Given this list of marker genes SLCO1B7, CETP, TSPO, PITPNM1, ABCA12, ANO4, ANO3, ABCA13, SLC10A4, TRIAP1, SERINC3, RFT1, CD36, VDAC2, PITPNC1, SLC10A6, STAR, SLC51B, SLC51A, CPTP, RBP4, ABCA7, SLC27A2, ABCD3, PITPNM2, SLC22A8, ABCA8, STARD5, ATP9B, SERINC5, ATP10A, STARD3, ATP11B, NPC1, ABCC3, ABCD2, ATP8A1, CIDEA, SLC22A6, ATP10B, SLCO2B1, APOD, SERINC2, PRELID1, XKR8, SLC43A3, ABCA2, APOA2, ABCA6, APOM, ATP8B2, APOB, SLC27A1, TMEM30A, PITPNA, ATP11C, ABCC11, AKR1C4, SLCO1B1 (solute carrier organic anion transporter family member 1B1), SCP2, CIDEB, ATP10D, XKR4, ATG2A, ANO6, OSBPL10, PLEKHA8P1, OSBPL5, ABCC1, ABCA1, ABCA5, SLC10A5, ANO9, ABCG8, TNFAIP8L3, SLCO1A2, SLCO4A1, SLC5A8 (NCBI Gene Id 160728), ABCG2, PRELID2, STARD7, SLCO2A1, BLTP1, ABCA3, PLSCR1, SFTPA1, ATP8B3, OSBP, APOF (NCBI Gene Id 319), TMEM30B (NCBI Gene Id 161291), SLC27A6, PCTP, TMEM63A, MFSD2B, OSBPL9, GRAMD1C (GRAM domain containing 1C), OSBPL1A, ATP9A, CERT1, VMP1, SLC2A1, PITPNM3, ATG9B, PRELID3A, SLCO1B3-SLCO1B7, PITPNB, SPNS2, FABP4, SLCO1B3, PLEKHA8, CLPTM1L, TMEM41B, CFHR4, NPC2, ATP8A2 (NCBI Gene Id 51761), ABCA10, SLC22A2, SLCO3A1, CEACAM1, APOC4, ABCB11, CLN3, SLC10A3, ARV1, APOA4, APOA5, XKR9, OSBPL2, ABCG5 (ATP binding cassette subfamily G member 5), ABCG1, SLC27A5, ABCD1 (ATP binding cassette subfamily D member 1), ABCA9, SLC10A2, ESYT1, APOE, OSBPL7, OSBPL8, PLSCR3, SLC22A1 (solute carrier family 22 member 1), SLCO1C1, ATG2B, SLC10A1, ABCA4, PLSCR2, STARD4, PLSCR4, GRAMD1A, TTPA (alpha tocopherol transfer protein), MTTP, PLSCR5, ABCD4, GLTP, ABCG4, APOL3, ATP8B1, C2CD2L (C2CD2 like), SLC27A4, SLC22A11, TMEM135, GRAMD1B, ATG9A, ATP8B4, ATP11A, PLTP, BLTP3B, FABP2, GLTPD2, ABCB4, GM2A, PRELID3B, OSBPL3, ABCB1, TMEM63B, APOA1, CIDEC, OSBPL6, FABP5, ABCC4, SLC22A7, SLC22A9, TMEM63C (NCBI Gene Id 57156), MFSD2A, FABP3, STRA6, here is a description of the gene set: species: Homo sapiens Human Gene Set: GOMF_LIPID_TRANSPORTER_ACTIVITY Enables the directed movement of lipids into, out of or within a cell, or between cells.